Given this list of marker genes KMT2A, EIF2S3, ACTB, TP63, SPTBN1, TAF1, PRIM1, TBX2, NAA10, KDM6A, FLNA, ALX4, CILK1, EXOC2, MUSK, UBAP2L, MYCN (NCBI Gene Id 53360), FANCL, PTCH1, PHF21A, EXT2, EPG5, COLEC11 (NCBI Gene Id 78989), ACTG1, KMT2D, POGZ, TGIF1, ZEB2, here is a description of the gene set: species: Homo sapiens Human Gene Set: HP_DEPRESSED_NASAL_TIP Decreased distance from the nasal tip to the nasal base. Depressed nasal tip